The following is a description of a gene set: Mouse Gene Set: GOBP_CELLULAR_RESPONSE_TO_STEROL Any process that results in a change in state or activity of a cell (in terms of movement, secretion, enzyme production, gene expression, etc.) as a result of a sterol stimulus. studied in species Mus musculus, and this is the list of marker genes: Gpr155, Ces1g, Insig1, Osbpl7, Dag1 (NCBI Gene Id 13138), Rora, Gramd1a, Lrp8, Ces1d, Gramd1b, Insig2, Ces1c, Dynap, Nfe2l1, Cyp7a1, Ces1a (NCBI Gene Id 244595), Ces1e, Ces1f, Ces1b, Ces1h, Gramd1c, Mlc1, Smo, Ptch1, Inhbb, Dynapl1, Lrp6 (NCBI Gene Id 77387), Gpld1, Rorc, Abca1, Inhba